The following is a description of a gene set: Mouse Gene Set: REACTOME_ADHERENS_JUNCTIONS_INTERACTIONS Adherens junctions interactions species: Mus musculus, and this is the list of marker genes: Cadm1, Afdn, Nectin4, Nectin1, Ilf3, Zeb2, Amot, Cdh12, Pvr, Cdh6, Hoxc8, Cdh15, Actb, Nectin2, Cdh9, Nectin3, Cdh4, Actg1, Sp1, Cdh17, Cdh7, Jup, Cdh10, Ctnnd1, Cdh3, Cdh24, Cadm3, Cdh18, Ctnna1, Cdh2, Adam19, Ang, Ctnnb1 (catenin beta 1), Cdh5, Adam33, Cdh13, Cadm2, Cdh8, Cdh11, Angptl4